Given this list of marker genes TAGLN2, SCHIP1, C5AR1, A2M, ADGRG2, ELF3, CSPG4, PPP2R2B, ALCAM, FHL1, MEOX1, COL9A3, NEDD9, NT5E, SMAD6, LOXL1, TRGV9, L1CAM, PPL, ARHGAP45, TNNC1, ADGRG1, TJP2, AXL, LMO1, CD9, GSN, NPR3, IGFBP6 (insulin like growth factor binding protein 6), ANXA8L1, HPSE, VTN, CAVIN3, COL5A1, SLC16A5, FABP3, LOXL2 (lysyl oxidase like 2), PLAU, SEMA3B, IL18, BMP5, SLCO3A1, DENND3, LAMB3, KRT17, AHNAK, OAS1, PCDH7, CADM1, CRIP1, FSTL1, DKK1, HDAC9, DUSP9, CRIP2, HSPB3, FLRT2, ENO3, INSL4, TRIM29, SNCA, here is a description of the gene set: Genes down-regulated in HeLa cells upon knockdown of MLL2 by RNAi. species: Homo sapiens ALR (MLL2) is a member of the human MLL family, which belongs to a larger SET1 family of histone methyltransferases. We found that ALR is present within a stable multiprotein complex containing a cohort of proteins shared with other SET1 family complexes and several unique components, such as PTIP and the jumonji family member UTX. Like other complexes formed by SET1 family members, the ALR complex exhibited strong H3K4 methyltransferase activity, conferred by the ALR SET domain. By generating ALR knockdown cell lines and comparing their expression profiles to that of control cells, we identified a set of genes whose expression is activated by ALR. Some of these genes were identified by chromatin immunoprecipitation as direct ALR targets. The ALR complex was found to associate in an ALR-dependent fashion with promoters and transcription initiation sites of target genes and to induce H3K4 trimethylation. The most characteristic features of the ALR knockdown cells were changes in the dynamics and mode of cell spreading/polarization, reduced migration capacity, impaired anchorage-dependent and -independent growth, and decreased tumorigenicity in mice. Taken together, our results suggest that ALR is a transcriptional activator that induces the transcription of target genes by covalent histone modification. ALR appears to be involved in the regulation of adhesion-related cytoskeletal events, which might affect cell growth and survival. Human Gene Set: ISSAEVA_MLL2_TARGETS from publication Issaeva I, Zonis Y, Rozovskaia T, Orlovsky K, Croce CM, Nakamura T, Mazo A, Eisenbach L, Canaani E (PMID 17178841)